The following is a description of a gene set: Any process that decreases the frequency, rate or extent of the regulated release of norepinephrine. Mouse Gene Set: GOBP_NEGATIVE_REGULATION_OF_NOREPINEPHRINE_SECRETION species: Mus musculus, and this is the list of marker genes: Agtr2, Ptgs1, Ghsr, P2ry12, Ptger3, Crh, P2ry1, Crhr2